The following is a description of a gene set: studied in species Homo sapiens Human Gene Set: GOCC_P_BODY A focus in the cytoplasm where mRNAs may become inactivated by decapping or some other mechanism. Protein and RNA localized to these foci are involved in mRNA degradation, nonsense-mediated mRNA decay (NMD), translational repression, and RNA-mediated gene silencing., and this is the list of marker genes: SYNE1, ELAVL1, PSMA2, RC3H1, IGF2BP2, LSM6, PSMA6 (NCBI Gene Id 87553), PSMC3, LSM14A, YTHDF3, AGO3, PUM1, LIN28A, YBX1 (NCBI Gene Id 7806), TRIM21, LIMD1, LSM3, APOBEC3D, IGF2BP3, DCP1A, MOV10, DCP2, APOBEC3C, TNRC6A, ZFP36, DDX6, MEX3B, CNOT8, FAM184A, EIF4E2, ZC3H12A, PSMC2, ZFP36L1, TNRC6C, CAPRIN1, RC3H2, CSDE1 (cold shock domain containing E1), EDC3, APOBEC3A, C9orf72, AGO2, LSM2, EIF4ENIF1, NANOS2, CARHSP1, PNRC1, BTBD2, GARRE1, CNOT1, AJUBA, RBPMS, UBAP2, EIF4E, HAX1, PAN3, MEX3A, UPF1, ISG20, AICDA, LSM4, PATL2, TNRC6B, SAMD4B, CNOT3, TRIM5, PNRC2, APOBEC3G, PATL1, WTIP, APOBEC3H, ZC3H12D, TOP1, YTHDF2, IGF2BP1, LSM1, CNOT2, SHFL, PAN2, NANOS3, SQSTM1, EDC4, APOBEC3B, CNOT9, APOBEC3F, TRIM71, NBDY, AGO4, YTHDF1, CNOT7, DIS3L2, XRN1, SAMD4A, PSMA4, CPEB1, BTBD1, DCPS, NOCT, DCP1B, AGO1, POLR2G